The following is a description of a gene set: Enlargement or increased size of the heart left ventricle. studied in species Homo sapiens Left ventricular hypertrophy Human Gene Set: HP_LEFT_VENTRICULAR_HYPERTROPHY, and this is the list of marker genes: AIP, SLC25A4, DBR1, MT-ND1, ZNF462, MT-CYB, COX16, GYS1, ESPN, BBS1, KCNJ5, TTR (NCBI Gene Id 7276), RIT1, WDR35, GNPTAB, MOGS, PIGA, CHST3, SPEG, TRMT10C, POMT1, FKRP, FZR1, ARSK, MT-CO3, BIN1, COG1, CACNA1D, GLRX5, LZTR1, SVIL, PLN, TLL1, MYL2, ABCA1, SLC25A24, RNU7-1, MT-TQ, POLG2, NEXN, MT-TF, HADHB, ZNF687 (NCBI Gene Id 57592), MYOZ2, COQ9, TWNK, FHL1, NPPA, GLA, TPK1, POLG, MT-TS2, DTNA (dystrobrevin alpha), SMAD3, JPH2, CCDC28B, MT-ND5, SCN5A, SCO1, COQ7, ACTC1, RYR1, DMD, MEN1, ACTN2 (NCBI Gene Id 88), ATP6AP2, PSEN1, HSD11B2, INSR, FBXL4 (F-box and leucine rich repeat protein 4), MT-ND6, GAA (alpha glucosidase), NEK8, SDHAF1, ADAM17, TNNI3, FLNC, NAXD, ARL6, C1QBP (complement C1q binding protein), MT-TL1, RRM2B, COL1A2, SDHB, GTPBP3, ABCC9, MTX2, LRPPRC, MT-TC, LOX, MYPN, MYL3, NDUFS2, MT-TV, MT-TW, EGFR, PSEN2, TTN, B3GAT3, HCN4, MT-CO2 (NCBI Gene Id 4513), MYH6, HADHA, EPG5, POMT2, NKX2-5, NONO, MT-TK, SDHD, LDB3, TCAP, MT-CO1, SDHA, TNNT2